Given this list of marker genes TRPA1, MTNR1B, FGF12, FMR1, GBA1, here is a description of the gene set: Any process that modulates the frequency, rate or extent of action potential creation, propagation or termination in a neuron. This typically occurs via modulation of the activity or expression of voltage-gated ion channels. Human Gene Set: GOBP_REGULATION_OF_NEURONAL_ACTION_POTENTIAL species: Homo sapiens